The following is a description of a gene set: from publication Chen Y, Wang X (PMID 31504780) Human Gene Set: MIR495_3P Genes predicted to be targets of miRBase v22 microRNA hsa-miR-495-3p in miRDB v6.0 with MirTarget v4 prediction scores > 80 (high confidence targets). studied in species Homo sapiens, and this is the list of marker genes: STK32B, RAET1E, TEAD2, KCMF1, RORB (RAR related orphan receptor B), HESX1, SLX4IP, DGKH, SHTN1, PCDH9, TMED9, TRIQK, ATP8A2, SEPTIN11, PICALM, MID2, SESTD1, GPR63, SLC41A3, ZFHX3, NUFIP2, NAV1, CCSER1, MED1, ZNRF2, SFPQ, GUCY1A2, GFPT1, PTPN2, ATF1, ARHGAP5, SNX30, NFYC, NRXN3, WIPF1, CACNA1D, SOWAHC, RAI2, TFAP4, SEC62, ZMYM2, R3HDM2, TMX3, ITGBL1, TMEM19 (transmembrane protein 19), NAPG, SESN3, CDK14, GAS1, LAGE3, GPR158, CAST, SDC3, TLE3, ARHGAP28, VGLL4, TMEM167A, WASHC4, MBTD1, TAFA2 (TAFA chemokine like family member 2), PHTF2, RHOBTB1, PEX26, SLC35F2, PHF21A, F2RL2, RC3H1, CERT1, INO80D (NCBI Gene Id 54891), DDX52, NFIA, ALG10B, HCCS, CANX, COL19A1, CDC6 (cell division cycle 6), RIMKLB, HMGCLL1, NCF2, LYPD6, U2SURP, SCG2, KDM5D, CREBZF, HMGXB4, SELENOI, DDIAS, IDI1, CERS6, STAT1, HIPK1, NLGN1, ATF7IP2, SOAT1, PLEKHG1, PHKG2, BCAP29, CCDC126, ITPK1, FGF7, DNAH7, SYT15, GTF2A1, PPM1D, GATA3, PBRM1 (NCBI Gene Id 55292), COL4A1, IL25, ZNF43, TRIP11, KDM2A, HNF4G, PCDHB9, FIGNL2, SPAST, NXPE3, CLDN10, PAPLN, C21orf91, SNRPB2, SUCO, SAP18, CYP26B1, CBX5, ARRDC3 (arrestin domain containing 3), TRPC1, LRRC25, ELAVL1 (NCBI Gene Id 1994), HSPA5, INSIG1, BACH2, SMNDC1, AIFM2, COPB1, MED12, PBOV1, ELL2, NUP62, IER2, SGCE, ZNF592, ITPR2, CRIPT, ZFR, PDE3A (NCBI Gene Id 8080), GRK3, DEPDC5, PPP4C, NCAM2, ALS2, TM9SF2, TESMIN, CELF2, KDM4A, OTUD7B, ABCE1, PDCL, CA13, ACTA1, FBXO28, HIVEP2, HTR1E, SCD5, FAT3, EXOSC8, AP4S1, SCEL, EEF1E1, ERCC6L2, DICER1, ATL2, SULT2A1, SLC17A6, PDE12, BMP7, PRELID3B, NFE2L3, CD9, STK4, PHLPP2, ZNF431, MDM2, PKD1L1, PTK2, PPP1CB, PLXNA4, PAF1, ATP2B2, BPIFC, PTPRJ, AGFG1, ARK2N, PPIP5K2, NQO2, WIPI2, FKTN, EPB41L3, PPP1R2, VEZF1, ZNF704, RMI1, PGAP1, RPRML, NEURL1, CDIN1, QSER1, ATRN, IGF1, UAP1L1, CREBBP, RBMS3, PCLO, PABPC5, SAR1B, LRP6, CNOT6, INPP4B, FNDC3A, COMMD3-BMI1, GAB1, RPRD1A, IL6R, NDUFB6, PRTG, EEF2K, FEM1C (NCBI Gene Id 84463), ANKIB1, KCTD16, PNISR, PROM2, SAMD4A, METTL4, PMP22, LIFR, UTP23, CPEB3, PRKX, CSRNP3, RBPJ, DNAAF5, SMIM7, HCN1, GPCPD1, ARHGAP19, SMAD9, CFAP44, MANEA, CDC14A, THRB, CPSF2, EIF4G3, FAM169A, CBX3, HTR2C, AREL1, PSME3, MALL, RHOU, RALGDS, TGIF2, PFKFB2, PAIP2, ST18, MINDY2, TFDP1, NCBP1, FNDC1, AQP4, RIMS4, STXBP5, CAND1, NR6A1, SENP6, CLCN5, NEXMIF, GORAB, HBEGF, PSMC6, NHLRC3, KLHL15, PELI1, TM9SF3, IRAG2, DCUN1D3, FUT1, TBL1XR1, ZFX (zinc finger protein X-linked), SFMBT2, PRKAA2, PDHA1, DCUN1D4, PRUNE2, CAMK2G, CDC37L1, BDNF, PIAS2, CDON, RPGRIP1L, NEK7, FGF5, SREBF1, TM4SF1, PRRG1, YOD1, MGRN1, NDUFS2, SPIN4, TNFRSF21, NUP62CL, ERI2, RPRD1B, CYTH1, POU3F1, CALU, PTPRA, UBE2D3, PRKAB2, SLC44A5, MECOM, BCL11A, HDAC9 (NCBI Gene Id 9734), TMX1, RUNX1T1, SCN2A, DPP8, TNFRSF1B, KLHL8, OPCML, REV1, CDKN1B, TEX261, UBE3A, ZNF273, LNPK, FCF1, AP1G1, KLHL11, PCM1, RAB18, SMC5 (NCBI Gene Id 23137), NLN (NCBI Gene Id 57486), ZNF548, NKAIN1, ACTC1 (actin alpha cardiac muscle 1), RBM46, SENP2, PPP4R3B, PGR, SZRD1, CAMTA1, RAVER2, NR2F2, GRWD1, CEP70, B4GALT6, RLF, SEPTIN8, KHDRBS2, SHOX2, PEX2, SH3BGRL2, CLIC4, BCL2L1, CSNK1E (casein kinase 1 epsilon), CTNND2, PCDH18, ZNF280C, CDC42SE2, AKAP12 (NCBI Gene Id 9614), NPAP1, TIGD6, GAGE1, NAALADL2, WDTC1, PRR11, TNRC18, EFCAB5, PRICKLE1, EVI5, GPR22, CPNE4, FOXK1, KCTD10, DMRTC2 (NCBI Gene Id 63946), KCNH5, ZNF292, SLC30A7, MTF2, TMEM64, ASB7, CUL4B, PNRC1, ZNF264, DMRT1, ANTXR1, PDE11A, UNG, POGZ, ZNF708, GOLGA7, FNDC3B, ZDHHC21, CPOX, SATB1, GTF3C3, PPP6C, MIB1, RPS6KA3, PHLPP1, ASB5, UBE2Z, TASOR, LAPTM4A, LRBA, IL1B, SNIP1, PSAPL1, KLK10, CBFB, FBXO30, AKAP6, RGS17, PRDM9, FRMD4B, NAB2, MEX3C, P4HA2, AKAP11, HSPA2, TTC6, USP15, DNER, ZNF280B, RAN, SEC24A, TMX4, PTPRE, PPHLN1, MYNN, NAA15, TRMT9B, MFAP3L, FZD4, PPP3CA, PCDH20, PAQR9, ILF2, MDC1, GFI1, MACROD2, HYCC2, KIF13A, CAB39, TTC28 (tetratricopeptide repeat domain 28), TMEM41B, FKBP5, HIGD1A, KLF8, ZNF850, FAM184A, ZBED4, ERCC6, CBFA2T2, JAZF1, STOX2, PLCH1, PIK3CB (NCBI Gene Id 5291), SLC2A14, ZBTB41, SEPTIN7, ZFHX4, PDLIM5, ZNF391, PTPN13, SH3PXD2A, C5orf22, TGFBR3 (transforming growth factor beta receptor 3), MLLT3, FGF14, SATB2, VPS35, ZNF281, MLEC, TAF1, ITM2A, ANKRD13C, MAPK9, MSI2, TNKS, ACBD7, DACT1, KLF3, ZNF518A, SHPRH, MEF2A, BROX, LCLAT1, AAK1, CCNT2, HOXA10, FBRSL1, UFM1, MS4A18, PTEN, TRIM32, TPD52L3, ONECUT2, TDRD1, NACC2, DNAJC6, NFAT5, MAOA (NCBI Gene Id 441491), CADM1, CEP170, OTUD6B, GLIS3, DCAF17, CCDC88A, ZMPSTE24, NOTCH2, CNTNAP4, SUPT16H, UBA52, UNC13C, ETS2, OTUD4, MGAT2, S1PR3, UBA6, GRM7, PASD1, CNBP, SLITRK2, ANKRD26, CDK6, SREK1, PRKAR1A, ARPC1A, OR2L13, KIAA0232 (NCBI Gene Id 9778), BCDIN3D, RICTOR, SUMO1, POU2F1, ZBTB20, PHF6, JUN, PTK7, CLOCK, TENM1, NRXN1, MTA3, UPB1, BAIAP2, ATXN7 (ataxin 7), PEX3, WBP1L, CDKN2B, CHD6, TENT5A, SCAI, PLCXD3, ACTR10, TIMM21, PCYOX1, MAST4, PHC3, NHLH2, RDH10 (retinol dehydrogenase 10), NABP1, GSE1, NIPBL, DUSP6 (NCBI Gene Id 1848), CLEC6A, WNK1, KMT2C, ELF1, EZR, NECTIN3 (NCBI Gene Id 25945), TMEFF2, NTNG1, GPM6A, SPEN, ZNF362, ARF6, XYLT1, DNAJC3, ZFAND5, NFIB, TMEM47, SLC7A14, ZBTB37, DENND1B, GOLPH3L, CADPS2, ELK4, SAMD12, BPNT2, HSDL2, MYEF2, C3orf33, VDAC2, TCF4, RLIM, CARD6, RBM12, MARCHF1, FAM91A1, PRKD3, MXRA7, UBN2, CMTM4, G3BP1, RASGRF2, VPS13D, ABHD13, SEL1L, ETS1, TMEM33, MYT1L, HJURP, HSP90AA1, MDH1B, PLAG1, TP53INP1, DDHD2, FBXW7, BUB1, SSX2IP, TMEM170B, GPR180, RBM20, FMN1, SLC16A10 (solute carrier family 16 member 10), FGF17, FGF2, MET, COPS7B, TMED2, TNRC6A, CAPS2, TMEM9B, PDE4D, SOX13, FAM133A (NCBI Gene Id 286499), ESM1, DDX3X, MPHOSPH9, NRBF2, TMEM39A, DCAF16, MINAR1, GPR155, CSPP1, LAMP2, EPCIP, PRR23C, AGBL4, PANK3, MKS1, DDIT4, ANKRD6, ENAH, KLF5, DENND5B, UNC5C, SMIM14, USP32, ITGA4, KHDRBS3, SENP1, LRRTM4, VGLL3, HTR1B (NCBI Gene Id 3351), ROBO1, PRKAG2, THSD7A, ANLN, TDRD5, KSR2, KANK4, VTA1, YTHDC1 (NCBI Gene Id 91746), CMPK1, THBS2, CELF1, GABRA1, SNAP25, KMT2A, LRRC4, STK17A, APOL6, NAPB, GMFB, GRIA3, TPTEP2-CSNK1E, NEUROD6, FUBP1, ZNF503, FOXO3, CXCL2, ZNF599, OSBPL8, SLC6A15, DNAL1